The following is a description of a gene set: Any process that modulates the frequency, rate or extent of the addition of telomeric repeats by telomerase. species: Homo sapiens Human Gene Set: GOBP_REGULATION_OF_TELOMERE_MAINTENANCE_VIA_TELOMERASE, and this is the list of marker genes: DCP2, TNKS2, TEN1, NAT10, CCT8, EXOSC10, CCT6A, HSP90AA1, ACD, PIF1, TINF2, TENT4B, STN1, PARP3, PARN (poly(A)-specific ribonuclease), NAF1, HNRNPC, HNRNPA1, CCT7, DKC1, ATM, PML, XRN1, SMG6, TERF2 (telomeric repeat binding factor 2), WRAP53, GNL3L, PINX1, ATR, CTC1, CTNNB1, POT1, FBXO4, HNRNPD, TP53, TNKS, CCT4, CCT5, SMG5 (NCBI Gene Id 23381), HNRNPU, TCP1, PTGES3, TERF1, CCT3 (chaperonin containing TCP1 subunit 3), CCT2